The following is a description of a gene set: Mouse Gene Set: TERAMOTO_OPN_TARGETS_CLUSTER_1 Cluster 1: genes whose up-regulation peaked one day after knockdown of OPN by RNAi in the NIH3T3 cells (fibroblasts) transformed by activated HRAS. Activated forms of Ras family members are prevalent in many cancers where Ras mutants transduce signals essential for transformation, angiogenesis, invasion and metastasis. As a cancer progression model, we used NIH3T3 cells to explore the mechanism of Ras-induced tumorigenesis. Ras family mutants H-RasV12 and Rit79L strongly induced foci formation, while Rho family mutants RhoA-QL, Rac1-QL and Cdc42-QL were less effective. A comparison of downstream transcriptional targets of Ras and Rho family members using a 26 383 element cDNA microarray revealed that the osteopontin (OPN) gene exhibited the best correlation between magnitude of gene expression change and level of foci formation (r=0.96, P<0.001). In association with H-RasV12- and Rit79L-mediated transformation, foci secreted OPN protein and upregulated the OPN receptor CD44, suggesting the novel initiation of an aberrant OPN-CD44-Rac autocrine pathway. In support of this were the following observations. First, RGD-deficient OPN protein-binding activity was present in H-RasV12-transformed cells but not in control cells, and binding activity was inhibited by the CD44 blocking antibody. Second, foci formation, cell invasion and Rac activity were induced by H-RasV12 and inhibited by the CD44 blocking antibody. Third, foci formation by H-RasV12 was substantially reduced by a short interfering RNA (siRNA) specifically targeting OPN expression for knockdown. Fourth, H-RasV12-mediated transformation was not blocked by the GRGDS peptide, suggesting that OPN effects were not mediated by the integrins. Lastly, OPN knockdown affected the downstream expression of 160 '2nd tier' genes, and at least a subset of these genes appears to be involved in transformation. Indeed, four genes were selected for knockdown, each resulting in a disruption of foci formation and/or invasion. These results underscore the role of aberrant autocrine signaling and transcriptional networking during tumorigenesis. from publication Teramoto H, Castellone MD, Malek RL, Letwin N, Frank B, Gutkind JS, Lee NH (PMID 15516973) species: Mus musculus, and this is the list of marker genes: Tfrc, Dclk3, Hmgcr, Sc5d, Fmr1nb, Plcd3, Tmem50b, Insig1, Lss, Erbb3, Actl6b, Gsta4, Bnip3, Gfod2, Idh1